Given this list of marker genes PLPPR4, PLPP5, LPIN2, PLPPR3, PLPPR5, PLPP6, PLPPR1, PLPPR2, PLPP1, PLPP2 (NCBI Gene Id 8612), LPIN1, PLPP3, LPIN3, PLPP4, here is a description of the gene set: studied in species Homo sapiens Human Gene Set: GOMF_PHOSPHATIDATE_PHOSPHATASE_ACTIVITY Catalysis of the reaction: a 1,2-diacylglycerol 3-phosphate + H2O = a 1,2-diacyl-sn-glycerol + phosphate.